Given this list of marker genes Bcl6, BC037156, Parp3, Foxp3, Ndfip1, here is a description of the gene set: Any process that stops, prevents, or reduces the frequency, rate or extent of isotype switching. Mouse Gene Set: GOBP_NEGATIVE_REGULATION_OF_ISOTYPE_SWITCHING species: Mus musculus